The following is a description of a gene set: species: Homo sapiens Metabolic alkalosis Human Gene Set: HP_METABOLIC_ALKALOSIS Metabolic alkalosis is defined as a disease state where the pH is elevated to greater than 7.45 secondary to some metabolic process., and this is the list of marker genes: HSD11B2, SLC26A3, KCNJ10, SLC12A1, CLCN2, SLC12A3, KCNJ5, NARS2, CACNA1D, HLA-B, BSND, IKZF1, SCNN1A, NR3C1, CLCNKA (chloride voltage-gated channel Ka), KCNJ1, SCNN1G, CLCNKB